Given this list of marker genes SLC26A2, SLC35B3, SLC26A11, PAPSS1, SLC35B2, SLC26A1, PAPSS2, here is a description of the gene set: species: Homo sapiens PAPS (3'-phosphoadenosine-5'-phosphosulfate), which functions as a sulfate donor in the cell, is synthesized from sulfate and two molecules of ATP in a two-step process (Robbins & Lipmann 1958) catalyzed in vertebrates by the bifunctional 3'-phosphoadenosine 5'-phosphosulfate synthase (PAPSS; Venkatachalam et al. 1998). PAPS synthesis takes place in the cytosol, and it is either consumed there in the sulfonation of a variety of hormones and xenobiotics, or it is transported to the Golgi apparatus and consumed in the synthesis of proteoglycans like chondroitin sulfate. Two isoforms of the human PAPSS are known, mutations in one of which are associated with defects in proteoglycan biosynthesis. Reactome Pathway: Transport and metabolism of PAPS part of: Glycosaminoglycan metabolism